The following is a description of a gene set: Human Gene Set: GSE8921_UNSTIM_VS_TLR1_2_STIM_MONOCYTE_3H_DN Genes down-regulated in monocytes (3h): untreated versus M. tuberculosis 19 kDa lipopeptide. In innate immune responses, activation of Toll-like receptors (TLRs) triggers direct antimicrobial activity against intracellular bacteria, which in murine, but not human, monocytes and macrophages is mediated principally by nitric oxide. We report here that TLR activation of human macrophages up-regulated expression of the vitamin D receptor and the vitamin D-1-hydroxylase genes, leading to induction of the antimicrobial peptide cathelicidin and killing of intracellular Mycobacterium tuberculosis. We also observed that sera from African-American individuals, known to have increased susceptibility to tuberculosis, had low 25-hydroxyvitamin D and were inefficient in supporting cathelicidin messenger RNA induction. These data support a link between TLRs and vitamin D-mediated innate immunity and suggest that differences in ability of human populations to produce vitamin D may contribute to susceptibility to microbial infection. from publication Liu PT, Stenger S, Li H, Wenzel L, Tan BH, Krutzik SR, Ochoa MT, Schauber J, Wu K, Meinken C, Kamen DL, Wagner M, Bals R, Steinmeyer A, Zügel U, Gallo RL, Eisenberg D, Hewison M, Hollis BW, Adams JS, Bloom BR, Modlin RL (PMID 16497887) species: Homo sapiens, and this is the list of marker genes: NUDT9, ALPK2, ZAP70, AEBP2, EPCIP, CSF1, MFHAS1, AMDHD2, CNDP2, PCMTD2, REXO4, TSPAN13, SIRT7, CYB5A, CCDC181, TINF2, SLC41A2, SLC25A19, ZNF565, FAM91A1, SUCLG1, STARD10, UBE2A, RNF11, NABP1, SEMA6D, NFATC2, ATP6V0D2, CHST12 (NCBI Gene Id 652072), ACSBG1, JUN, BORCS5, JTB, PDPN, KHNYN, PFKFB3, BTBD7, SYS1, ACADS, PRDM10, TIAM1, SBNO2, RFXAP, IST1, IDS, MAPK3, APPL2, B3GNT2, TMEM35B, IGFBP4, CPLANE1, RNF181, RNF214, RBMS2, HDAC5, ARPC1A, SLC25A24, TRIP4, SH2B1, ARMCX4, PLCG1, ZC3H12D, UPF2, BBS12, ARAP1 (ArfGAP with RhoGAP domain, ankyrin repeat and PH domain 1, NCBI Gene Id 23290), MOB3B, PML, WWP2, TECPR1, IL4R, ATG2B, HSD17B10, MAPK11, SARS2, VPS28, NOB1, GPR155, MDP1, FAM234A, CERS4, SLC9A1, COASY, NAGA, CRTC3, FCHSD2, FAM217A, PJA1, NDST2, NXPE3, AKIRIN1, EPM2AIP1, RAB18, RINL, MBD2 (NCBI Gene Id 8932), CCNL2, ACVR2A, BCL2L15, MAPK9, TMEM176B, PRDX5, SSBP4, CLOCK, MXI1, LPXN, ELOVL6, CCDC88C, PLCB3, G2E3, MROH1, TWF2, DDR1, PPFIBP1, DNAJB2, RNH1 (NCBI Gene Id 6050), PYGO2, STX7, ITPK1, NDRG3, KIF3A (NCBI Gene Id 11127), DIPK2A, ACOX1, ITGB7, NAPEPLD, TMEM74B, GOLM1, RPS7, ZNF652, UFL1, CDS2, DNAJB5 (DnaJ heat shock protein family (Hsp40) member B5), IL12RB1, ATP6V1E1, RIPOR2, WNT5B, ANXA4, ANAPC4, LAMP1, ALDOC, MFSD2A, C15orf48, SORBS3, PYGB, TSPAN14, HDAC4, FURIN, CREG2, PIK3CG, KDELR3, IQGAP2, MTSS1, LCN12, STN1, LDHD, CYP4F12, TCP11L2, PKD1, CHMP5, RHOC, FLNA, WDR81, TNIP2, ADAMTSL4, LAT2, SYNRG, ABI3, ARHGAP45, TGFB3, MARCHF2, TSR3, SNHG8, ALG5, AKAP12, SLC4A2, UIMC1, ANKIB1, PGAM1, ZDHHC24, NGRN, ARL4C, IRF2BPL, AP3D1, IFT43, GABBR1, PARD6B, SRI, ASL, TNFRSF25, DDI2, R3HCC1L, PRNP, APLP2, ZNF579, RAPH1, CCN1, NCMAP, XPNPEP1, ATRNL1, MTMR12, NAA16, BMP1 (NCBI Gene Id 649)